The following is a description of a gene set: studied in species Homo sapiens A process in which a protein is transported to, or maintained in, a location within a motile cilium. Human Gene Set: GOBP_PROTEIN_LOCALIZATION_TO_MOTILE_CILIUM, and this is the list of marker genes: DNAH11, DNAAF11, EFCAB7, ODAD4, CFAP58